Given this list of marker genes PTPN22, NCF2, PRTN3, HLA-DPA1, HLA-DPB1 (NCBI Gene Id 3115), STAT1, CTLA4, here is a description of the gene set: Human Gene Set: HP_PULMONARY_NODULE Focal rounded or ovoid opacity, not more than 3 cm in diameter. Pulmonary nodules are typically observed by chest radiography or computer tomography imaging. species: Homo sapiens Pulmonary nodule